The following is a description of a gene set: from publication Chen Y, Wang X (PMID 31504780) species: Mus musculus Mouse Gene Set: MIR_7063_3P Genes predicted to be targets of miRBase v22 microRNA mmu_miR_7063_3p in miRDB v6.0 with MirTarget v4 prediction scores > 80 (high confidence targets)., and this is the list of marker genes: Ntrk2, Ccdc43, Oprm1, Mup1, Gpc6, Efemp1, Pilra, Cep76, Ammecr1, Mis12, Mtus1, Tmed8, Irag1, Fam167b, Ms4a1, Pigh, Zfp418, Rprd2 (regulation of nuclear pre-mRNA domain containing 2), Exoc6b, Ythdf1, Acin1, Plp1, Bag5, Klf14, Hes1, Mdfic, Pde7a, Marchf6 (membrane associated ring-CH-type finger 6), Gpbp1l1, Trappc3, Cdk14, Rufy3, Mtmr4 (NCBI Gene Id 170749), Nfatc2, Pdgfc, Tbc1d22a, Zfp11, Ephb3, Fyn, H2bw2 (H2B.W histone 2), Magea13, Exd1, Dhdh, Fbxw8, Ak5, Ak3, Ar, Mup2, Lpin2, Trpm3, Pbxip1, Hoxa9, Raph1, Mat2a, Sh3glb1 (SH3-domain GRB2-like B1 (endophilin)), Lrch3, Gpr161, Mecp2, Ddt, Hdac9, Ppp1cc, Cnst, Usp33, Spint2, Slc17a6, Cyp2j13, Tnik